The following is a description of a gene set: Human Gene Set: REACTOME_PARACETAMOL_ADME species: Homo sapiens Paracetamol ADME, and this is the list of marker genes: ABCC5, ACY1, SULT1C4, SULT1A3, NAT1, CYP2E1, GSTM1, ABCC2, UGT1A9, ABCC3, SULT1A4, CNDP2, GSTT1, SULT2A1, GGT7, UGT1A10, SULT1E1, ABCC1, NAT2, GGT1, UGT1A6, GGT6, ABCC4, UGT1A1, ABCG2, UGT2B15, GGT5, GSTP1, SULT1A1